The following is a description of a gene set: Mouse Gene Set: GOBP_PLACENTA_BLOOD_VESSEL_DEVELOPMENT species: Mus musculus The process whose specific outcome is the progression of a blood vessel of the placenta over time, from its formation to the mature structure., and this is the list of marker genes: Plcd1, Map2k1, Mapk1, Notch2, Akt1, Socs3, Pkd1, Plg, Apela, Wnt2, Prl7d1, Hes1, Rbm15, Arid1a, Junb, Syde1, Esx1, Pkd2, Fbxw8, Rbpj, Vash1, Hey1, Fosl1, Wdr83, Ccn1, Ggnbp2, Synb, Nfe2, Fzd5 (NCBI Gene Id 98335), Hey2, Ovol2, Spint1, Llgl2, Nsdhl, Ncoa6, Plcd3, Tmed2, Nr2f2, Vash2, Hs6st1